Given this list of marker genes ADAMTS1, ADAMTS20, SPON2, ADAMTS19, ADAMTS14, SBSPON, ADAMTS8, CFP, THSD7B, ADAMTS12, ADAMTS10, ADAMTS17, ADAMTS13, ADAMTSL2, THSD4, THSD7A, ADAMTS6, ADAMTS16, SEMA5A, POFUT2, B3GLCT, ADAMTS2, SPON1, ADAMTS18, SEMA5B, ADAMTS7, ADAMTSL1, ADAMTS9, ADAMTS3, ADAMTS4, THBS2, THBS1, ADAMTSL4, ADAMTS15, SSPOP, THSD1, ADAMTSL5, ADAMTSL3, ADAMTS5, here is a description of the gene set: The O-fucosylation of proteins containing thrombospondin type 1 repeat (TSR) domains is an important PTM, regulating many biological processes such as Notch signalling, inflammation, wound healing, angiogenesis amd neoplasia (Adams & Tucker 2000, Moremen et al. 2012). Fucose addition is carried out by two protein fucosyltransferases, POFUT1 and 2. Only POFUT2 recognises the consensus sequence CSXS/TCG found in TSR1 domains and the fucosyl residue is attached to the hydroxyl group of conserved serine (S) or threonine (T) residues within the consensus sequence. The modification was first demonstrated on thrombospondin 1, found in platelets and the ECM. The resulting O-fucosyl-protein is subsequently a substrate for beta-1,3-glucosyltransferase-like protein (B3GALTL), which adds a glucosyl moiety to form the rare disaccharide modification Glc-beta-1,3-Fuc. More than 60 human proteins contain TSR1 domains, The disaccharide modification has been demonstrated on a small number of these TSR1 domain-containing proteins such as thrombospondin 1, properdin (Gonzalez de Peredo et al. 2002) and F-spondin (Gonzalez de Peredo et al. 2002). The ADAMTS (a disintegrin-like and metalloprotease domain with thrombospondin type-1 repeats) superfamily consists of 19 secreted metalloproteases (ADAMTS proteases) and at lease five ADAMTS-like proteins in humans. Five members of the ADAMTS superfamily have also had experimental confirmation of the disaccharide modification. Examples are ADAMTS13 and ADAMTSL1. In the two reactions described here, the TSR1 domain-containing proteins with similarity to the experimentally confirmed ones are included as putative substrates. part of: O-linked glycosylation species: Homo sapiens Reactome Pathway: O-glycosylation of TSR domain-containing proteins